Given this list of marker genes XRCC4 (NCBI Gene Id 7518), XRCC5, PRKCD, TIPARP, LIG4, CLU, PTPN1, CASP3, PPA1, PPP5C, C1D, MDC1, PPP2CA, here is a description of the gene set: Proteins that regulate activity of PRKDC. Human Gene Set: COLLIS_PRKDC_REGULATORS species: Homo sapiens Double-strand breaks (DSBs) arise endogenously during normal cellular processes and exogenously by genotoxic agents such as ionizing radiation (IR). DSBs are one of the most severe types of DNA damage, which if left unrepaired are lethal to the cell. Several different DNA repair pathways combat DSBs, with nonhomologous end-joining (NHEJ) being one of the most important in mammalian cells. Competent NHEJ catalyses repair of DSBs by joining together and ligating two free DNA ends of little homology (microhomology) or DNA ends of no homology. The core components of mammalian NHEJ are the catalytic subunit of DNA protein kinase (DNA-PK(cs)), Ku subunits Ku70 and Ku80, Artemis, XRCC4 and DNA ligase IV. DNA-PK is a nuclear serine/threonine protein kinase that comprises a catalytic subunit (DNA-PK(cs)), with the Ku subunits acting as the regulatory element. It has been proposed that DNA-PK is a molecular sensor for DNA damage that enhances the signal via phosphorylation of many downstream targets. The crucial role of DNA-PK in the repair of DSBs is highlighted by the hypersensitivity of DNA-PK(-/-) mice to IR and the high levels of unrepaired DSBs after genotoxic insult. Recently, DNA-PK has emerged as a suitable genetic target for molecular therapeutics such as siRNA, antisense and novel inhibitory small molecules. This review encompasses the recent literature regarding the role of DNA-PK in the protection of genomic stability and focuses on how this knowledge has aided the development of specific DNA-PK inhibitors, via both small molecule and directed molecular targeting techniques. This review promotes the inhibition of DNA-PK as a valid approach to enhance the tumor-cell-killing effects of treatments such as IR. from publication Collis SJ, DeWeese TL, Jeggo PA, Parker AR (PMID 15592499)